Given this list of marker genes SLC9A4, SLC17A6, SLC9A9, SLC9A3, SLC9A6, SLC9A8, SLC17A7, SLC9A7, SLC9A2 (solute carrier family 9 member A2), SLC9C2 (solute carrier family 9 member C2 (putative)), SLC9A5, SLC9C1, SLC9A1, TMCO3, here is a description of the gene set: Human Gene Set: GOMF_POTASSIUM_PROTON_ANTIPORTER_ACTIVITY studied in species Homo sapiens Enables the transfer of a solute or solutes from one side of a membrane to the other according to the reaction: K+(in) + H+(out) = K+(out) + H+(in).